Given this list of marker genes NALCN, CTSC, DSP, SPTBN1, UNC80, ADAMTS15, here is a description of the gene set: Tapered distal phalanges of finger species: Homo sapiens A reduction in diameter of the distal phalanx of finger towards the distal end. Human Gene Set: HP_TAPERED_DISTAL_PHALANGES_OF_FINGER